The following is a description of a gene set: species: Mus musculus The directed movement of proline, pyrrolidine-2-carboxylic acid, across a membrane by means of some agent such as a transporter or pore. Mouse Gene Set: GOBP_PROLINE_TRANSMEMBRANE_TRANSPORT, and this is the list of marker genes: Slc6a7, Slc1a4 (solute carrier family 1 (glutamate/neutral amino acid transporter), member 4), Slc36a3, Slc38a2, Slc6a20a, Ace2, Cltrn, Slc6a20b, Slc36a2, Slc7a8, Slc36a1